Given this list of marker genes COX4I2, SMPD2, GSR, MED14, NEU4, CPNE1, TAT, NUP205, INS, DCXR, MAOB, PXMP2, AKR1C1, ADH4, GPS2, SLC25A32, ATIC, COQ9, GGT5, PLEKHA4, PIK3CD, DSE, NADK2, BCAT2, COQ8A, MPST, PCK1, MTF1, B4GALT1, ENO4, DUOX1, BMX, OGN, AGL, ETHE1, RAE1, NDUFA13, PM20D1, GCHFR, PSMA6, OMD, UGT2B7, NUP155, HS2ST1, LRP12, PIK3R1 (phosphoinositide-3-kinase regulatory subunit 1), ADH7, TH, NAALAD2, NT5C3A, TBXAS1, UQCRQ, SACM1L, CYP2D6, MPC2, CTH, SLC25A17, SLC25A15, THRAP3, B3GNT4, PIP4K2B, ST3GAL2, SLC46A1, DGAT2L6, RPS6, ST3GAL5, GPC4, PNKD, ODC1, MED24, NCOR2, RHCE, GSTM5, PGLS, CARNMT1, 5.8S rRNA, GYG1, HYAL4, NNT, ALOXE3, MSMO1, GAMT, LPIN2, IMPDH1, PSMC3, PRKACG, PSMB6, AGMAT, PKM, RBP1 (NCBI Gene Id 5947), HAS3, GSTT2, NSDHL, ACSF2, VAPA, OXCT1, UGT2A3, UGT2B11, HILPDA, PFKL, PECR, GPX1, HPGDS, PLCB3, PLAAT4, APOA1, NMT1, BLVRB, INPP5D, ACMSD, MED30 (NCBI Gene Id 90390), ACP6, RPS29, DDHD1, PDZD11, ABHD10 (abhydrolase domain containing 10, depalmitoylase), TTPA, NDUFB11, RPL39L, NME1, PSMC2, MIOX, SGPP1, GPAM, PI4KB (phosphatidylinositol 4-kinase beta), NEK1, TRIB3, COX6B1, UST, NADSYN1, RPL22L1 (ribosomal protein L22 like 1, NCBI Gene Id 553116), PIK3CG, BCKDK, TECRL, PSMD2, CYP1A2, COX7A2L, HAAO, VNN1, ADSL, GK3, GNG3, CHST15 (NCBI Gene Id 9916), PEX11A, HS6ST3, BST1, ACOT8, APIP, AKR1E2, CSAD, PITPNM2, PIK3CB, OSBPL7, SCP2, NOSIP, ACER1, GCLM, CPNE7 (copine 7), NDUFB7, CYP2F1, MBOAT2, RMND5B, SEPHS2, HK2 (hexokinase 2), PLA2G5, MED29, EBP, GATM, IDH2, GDPD3, RPL5, CYP2R1, HS3ST2, GSTA1, CHST14, UBC, PLAAT1, ADSS2, SLC23A2, STARD5, ACY3, ALOX12B, CLOCK, AMN, SAT1, HKDC1, DGUOK, ASNS, FBP2, ORMDL3, ACBD7, NAGLU, NAMPT, GNA14, SQOR, RPL11, HMGCR, PRELP, PSMA5, AKR1B1, RPL39, NFS1 (NCBI Gene Id 96810), FECH, SERINC2, NDUFS6, MTMR1, RPS9, SEM1, RPIA, GSTA5, LDLR, COX8C, CYP2B6, AMACR, PIP4K2C, GPT, TIAM2, SERINC1, SYNJ1, MCEE, AZIN1, GPX2, RPS7, TSTD1, MED1 (mediator complex subunit 1), MT-CO3, SLC36A4, RAN, FAM20B, AGPS, ACADS, CSGALNACT1, GNGT2, OAZ3, NUDT16, PSMA4, MCCC1, ARSD, SDC2, EXT2, MMADHC, RRM2B, PDP1 (pyruvate dehydrogenase phosphatase catalytic subunit 1), ACOT2, PSMD8, EXTL2, CHSY1, B3GNT7, DCAKD, ADH1B, SARDH, APOC2, TECR, MAT1A, LRP2, PANK1 (pantothenate kinase 1), CAV1, TPH2, SDHD, CHRM3, ADPRM, GALT, CPOX, COX11, GSTA4, NMRK1, GNAQ, CDIPT, RPL36A, PON2, DBI, L2HGDH, RPS19, CYP19A1, CYB5B, UGT1A9, HSPG2, HSD17B8, MED19, MT-ND4, GNG4, RPS16, ACAD9, NDUFAB1, NQO2, ARSI, PLPP2, BCKDHA, NAXD, PSMC1, SYNJ2, ENTPD2, PLA2G10, OAT, AMPD3, PTDSS1, SDS, OAZ2, SLC27A5, RPL9, UGT1A5, CSNK1G2, DCTD, RPS15A, MOGAT3, SLC22A13, PCYT2, ALOX15, NME3, ACSL1, TPST2, SCO2, OSBPL1A, ESD, PIP5K1B, AGRN, RPL36, AADAC, CACNA1D, GGT7, DBT, NUP85, CYB5R3 (cytochrome b5 reductase 3), SERINC5, SUCLG1, GBA1, ENTPD1, D2HGDH, HMGCS2, PLA2G4B, UGT3A2, GSTO2, SEC24C, GLUD1, MED25, STARD3, CYC1, HMBS, HIBADH, ALOX15B, SEPSECS, CYP26B1, HSD17B10, GLA, INPP5J, LYPLA1, PSMB2, TPK1, APOA2, INPP1, FIG4, DMAC1, PIK3C2G, SURF1, RPL15, AS3MT, HMOX1, HSD17B3, COX17 (cytochrome c oxidase copper chaperone COX17), EEFSEC, CYP4F22, AUH, CYP2A7, NUP35, RPLP0, ITPK1, NUP43, PLEKHA1, ALAS2, NDUFC1, ME1, GPAT4, PPIP5K2, DGAT2, RPL31, CTPS1, PSMB5, LIPE, ECSIT, UCP3, FUT9, FUT4, LDHC, AKT1, SIN3A (NCBI Gene Id 25942), PCBD1, FH, ALAS1, CYP4A11 (NCBI Gene Id 1579), SHMT2, UQCC2, UQCRFS1, MTMR8, GLB1L2, GLYATL3, SMOX, IDI2, DHRS7B, HSP90AB1, OSBPL9, PARP8, HACL1, ADH6, AGPAT3, NDUFS3, PLCH2, HOGA1, ISYNA1, RPS12, INPP5B, VAMP2, ATP5MJ, LDHAL6B, RPS8, SLC25A2, CHST9, ACAD10, NDUFA2, ADCY4, CGA, GPC5, POR, RPL26L1 (NCBI Gene Id 51121), NQO1, INSIG1, TMLHE (NCBI Gene Id 55217), ELOVL3, FMO1, FDFT1, GNAI1, GDPD5, FABP12, SPTSSA, NDUFB1, 28S rRNA, SMPD1, AK7, SQLE, IARS1, PTGR2, NDST2, AGPAT1, LETM1 (NCBI Gene Id 3954), NUDT15, PANK4, FUT1, HMOX2, CYP2C18, AKR1D1, PPP2R1B (protein phosphatase 2 scaffold subunit Abeta), PARP16, DPYD, RPL22, ADCY8, TACO1 (translational activator of cytochrome c oxidase I), RMND5A, ARF3, GOT1, AK1, CACNB2, PITPNB, HPDL, NUDT13, CERS5, SLCO1A2, PPP2CB, PIAS4, TIMM21, ENTPD6, TST, GSTM2, PLA2G4D, DCT, CA7, CKB, NR1H4, GDPD1, PTGDS, ATP5PB, SUCLG2, PLA2G4E, NR1H2, UQCC3, UCK2, PAH, AOC1, RPS2, NDUFA11, PRKAR2A, PGS1, PFKFB1, ACY1, SLC25A18, PISD, CTRB2, PANK3, ST3GAL3, PIPOX, GLRX, BHMT2, INPP5F, FAR1, ACAT2, TBL1X, NDUFAF8 (NADH:ubiquinone oxidoreductase complex assembly factor 8), ACOT9, PLCG2, NUDT18, LTC4S, NT5C, CDS1, CD44 (NCBI Gene Id 960), SPAM1, CPNE3, PSMA3, RPL7, NUDT10, AHCYL1, SNAP25 (synaptosome associated protein 25), BPNT2, PNPLA8, HELZ2, IL4I1, FAU, MOCS1, PIK3R6, FABP4, PPA1, MED17, NUP58, GSTT2B, UGDH, CYP39A1, NUP133, ACSBG2, SULT6B1, RBKS, RPL32, SUCLA2, SLC35D2, GLS, CYP51A1, PGK1, DHCR7, HSD11B1, KCNJ11, PNP, NUP214, DNM2, AOC2, MED31, UQCR10, GNAI2, ACADSB, PSMB3, PSMA1, AKR7A3, OPLAH (NCBI Gene Id 55579), NDUFS5, GLB1L3, ARG1, FUT6, MDH1, GGPS1, MLX, WDR26, PSMD6, ALDH1A1, ENO3, MARCKS, CBR1, GNG12, CES1, ALDH1B1, HS3ST3A1, PFKM, TPMT, ACOT7, GADL1, HAO2, PLPP3, SULT1E1, STAR, PPP2R5D, ABCA1 (ATP binding cassette subfamily A member 1), RFK (NCBI Gene Id 55312), ACAN, DEGS2, HSD11B2, B3GAT2, PNPLA6, GNB5, PANK2, COX6A2, PIP5K1C, AKR1A1, NDUFB4 (NCBI Gene Id 727762), CYP26A1, PLEKHA6, PIK3C2B, CYP27A1, RRM1, AMT, ACLY, CDO1, CA6 (carbonic anhydrase 6), MED21, SULT2A1, PLPP1, MT-ND3, MAT2B, CACNA1E, FDX1, SLC51A, BAAT, ACSM6, FDPS, RPL35, DIO3, ALDH2, ECI2, PLCB4 (NCBI Gene Id 5332), SULT2B1, NUDT5, B4GALT3, SLC26A1, FAH, ATP5PO, LPL (NCBI Gene Id 4023), ARSF, FOLH1, RPS21 (ribosomal protein S21), NDUFA1, HAL, SLC26A2, NUBP2, CYCS, DEGS1, ELOVL4, CACNB3, PPARGC1B, AK8, RPL6, GSTM4, CHST3 (NCBI Gene Id 9469), ACSS1, ARSL, PARP9, SLC25A13, ADPGK, RPS13, ATP5ME, RAB14, ACOXL, XYLT2, RIDA, FITM1, SPTLC1, NDOR1 (NCBI Gene Id 648245, NADPH dependent diflavin oxidoreductase 1), FITM2, MED18, COASY, MOCOS, MOGAT1, FABP1, NUDT9, DLAT, ADCY7, MED4, TYMS, CHST1, CA1, RPS27, AGK, CA14, COX7C, PRKACB, RPS24, NDUFB3, CYP2C19 (cytochrome P450 family 2 subfamily C member 19), COMT, SEC23A, ACACB, NMNAT2, CD36 (NCBI Gene Id 948), NDUFS7 (NADH:ubiquinone oxidoreductase core subunit S7), KYAT3, CA5A, NMRAL1, PYGB, CYGB, PLBD1, RPS23, CSPG4, GC, COX8A, ADCY1, RPL23A, AGXT, PFKFB2, PLA2G4F, COQ8B, ABCD4, VNN2, FABP6, IP6K1, AACS, HPSE, NT5C1A, INPP5E, ACP5, AMD1, PIK3C2A, CAD, SCAP, STS, CD38 (NCBI Gene Id 952), UGT1A3, CYP24A1, ME3, SLC25A51, NDUFS1, ABHD4, SLC27A2 (solute carrier family 27 member 2), CIDEC, ALDH3A2, NDUFAF7, UGT2B10 (UDP glucuronosyltransferase family 2 member B10), GOT2, GPD2, MTM1, NR1D1, TK1, MED22, PIK3C3, PRPS2, INPPL1, AZIN2, KERA, SLC35B3, CBLIF, CYP2C8, HK3, CYP46A1, MTMR6, DMAC2L, RPL19, DDAH1, SLC25A14, RPL37, SIRT5 (NCBI Gene Id 285813), 5S rRNA, UPP2, CEMIP, CHSY3 (NCBI Gene Id 337876), IPPK, IPMK, MAT2A, RPL18A, IVD, PIK3R5, UGT1A8, PDK2, CHST7, TSHB, INPP5A, DARS1, GCK, BGN, HADHB, STARD6, B3GALT2, GLIPR1, SLC25A44, RPL30, CERS3, GCG, NUP107, FUT5, TKT, GSTM1, CERS1, GGT6, RPE, PNPLA7, B3GALT5 (NCBI Gene Id 105372805), PRPS1, PLA2G6, PLEKHA8, ALDH7A1, PLIN1, CERS2, GNG13, PUDP, ELOVL5 (ELOVL fatty acid elongase 5), ERCC2, AK9, POM121, HAO1, CYP1B1, FDX2 (NCBI Gene Id 2143), UGT2B15, SPHK2, RPL10, INMT, B3GNT2, STARD3NL, SLC37A4, MMUT, COQ7, RPL18, NUDT4, UQCRB, RPL37A, HAS2, GGT3P, UQCRHL, ENPP2, STAB2, NMRK2, GGCT, NPAS2, NUP160, HEXA, PDXK, RPSA, AK5, NDUFA6, CYP17A1, NDUFB9, LPIN1, CYP7A1, FTCD, UCP1, TNFAIP8L2, CHST5, MT-CYB, ANKRD1, HYKK, NDUFA7, BCO1, AHR, CSNK2A1, UGT2A1, CA12, ACSF3, SUMO2 (small ubiquitin like modifier 2), PRSS3, HMMR, PC, TXNRD1, NDC1, ADCY2, PSMB4, ADI1, BCO2, XYLT1, CYP4F3, A4GALT, RPL12, SEC24D, PLB1, SLC52A2, CYP11B1, PTGES3, FAHD1, ACOT13, TMEM126B, PLD2, GUK1, CHAC1, NUDT3, GMPR, PRKACA, RUFY1, PYCR3, PLA2G2E (phospholipase A2 group IIE), PGM2, MTHFD2L, DCTPP1, DIO2, BTD, OCRL, SMARCD3, GCH1, PPIP5K1, PLA2G15, SREBF1, GALC, B3GALT6, ACAA2, SLC25A37, AOC3, SDHC, HIGD1C, SERPINA6, NRF1, RPL27, HYAL1, PLD1, CYP2U1, CYP7B1, TPH1, IDI1, FLVCR1, GCSH, CD320, ALDH4A1, SULT1C4, G6PC2, MTRR, CHAC2, MED7, PDPR, ABO, STARD10, GPC2 (glypican 2), DHFR2, UGCG, UPB1, GPC3, GNA15, PPM1K, APOA5, LRAT, SLC44A1, ITPR3 (NCBI Gene Id 3710), CCNC, TP53, GSTT1, CYP2S1, GNG5, EPHX2, UQCRC1, SARS1, GYS1, PSMC6, LPCAT1, HGD, CIAO1, PARP4, ACOT1, HSD17B14, AIMP1, LGMN, CSNK2B, AANAT, SDSL, THEM4, DDO (NCBI Gene Id 8528), SLC52A1, TPST1, PGAM2, UBB, AK6, GPC1, ACAD8, HCCS, COQ10A, ETFA, PPAT, HSD17B4, ENOPH1, RARS1, ORMDL2, RPLP2, CSPG5, ATP5MC2, CALM1, HSD17B2, GNA11, RPL38, CYP2J2, PAOX, DTYMK, PHKA1, UBIAD1 (UbiA prenyltransferase domain containing 1), PRKAR1B (NCBI Gene Id 645590), SECISBP2, PYGM, CRYM, HSD3B2, PGD, NFYB, SLC2A1, RRM2 (NCBI Gene Id 6241), PODXL2, ATP5MC3, ATP5PD, MORC2, SERINC4, SLC6A7, GLP1R, FMOD, PPP1R3C, TNFAIP8, PSMD1, AKR1B15, HAGH, ADH1A, ACSL4, NUP42, GMPR2, IQGAP1, APOA4 (NCBI Gene Id 337), CHST6, ENTPD5, PSMB7, AK4, SC5D, MTHFD1, SLC19A2, NUP50, AADAT, TRMT112, AGPAT2, UQCRC2, TRAP1, G6PD, FADS2, DMAC2, MTARC2, SLC5A5, MBTPS2, VDAC1, HS3ST4, RPL34, PGM1, PXYLP1, DECR1, CHDH, MED10, PARP6, PSMC4, SPR, FLAD1, PITPNM1, OLAH, SPTSSB, DERA, TXN, LPCAT3, NNMT, LHB, UQCC1, TNFRSF21, STK11, RPL14, CUBN, B3GAT1, FABP5, UQCRH, PDHB, RAB5IF, BBOX1, RPS15, MMACHC, HACD2, NUP153, PCK2, ELOVL1, NT5C1B, PSMD3, PLAAT2, ADA, GID4, GMPS, PPM1L, NUBP1, DPEP1, CYP2C9, ABCC8, RPL13A, ALOX5AP, RPL10A, GSTO1, GART, SLC25A21, NDUFB6, CA3, CYP3A4, STXBP1, MT-ND2, SRD5A2, COQ2, RPS3, PTGES, ATP5MF, GAPDH, ISCA2, MT-ATP6, UQCC5, CBR3, ADCY6, CSKMT, ATP5MK, FHL2, GYS2, UGT1A1, STARD7, AKR1C4, CHST13, DDHD2, HACD3, PLCB2, AKAP5, PPARA, MED27, INPP4A, POM121C, CA9, COA3, SGMS1, AMDHD1, SLC22A5, HIGD2A, NT5C2, CYP11A1, UGT1A4, ADIPOQ, KPNB1, SLC35D1, CA4, NUP62, HSD17B12, SDHAF3, B3GNT5, CIAO2B, TYMP, PLAAT5, GNAS, DLD (NCBI Gene Id 2654), PNPO, SDC1, CA2, COX6C, GID8, SLC37A1, ACSM2B, FOLH1B, CMBL, CERT1, ACOX1, THEM5 (thioesterase superfamily member 5), ALDH1L1, GNG8, COX5A, IDO2, PNPLA2, OXCT2, GALNS, MINPP1, MAOA, APOB, UROS, GLB1, SLC6A12, OSBPL10, SDC3, DBH, ZDHHC21, CARNS1, IMPA2, RPL35A, GLUD2, GK, CYP4V2, HK1, PHKG1, ETNK1, SLC5A8, ADCY5, SRM, PMVK, ATP5MC1, PLA2G3, FABP7, PEMT, TYRP1, HADHA, TGS1, MBTPS1, NDUFS8, SLC44A4 (solute carrier family 44 member 4), EPM2A, PET100, ACER3, RPL17, MED26, ENTPD4, GPC6, ADCY9, PRKAA2, HSD17B7, ABCC5, OSBPL8, ACSBG1, PRKCA, HSPA9, PTS, PYCR2, CSGALNACT2, CHD9, PRXL2B, IP6K2, ENPP3, SLC22A4, ITPR1, SLC17A5, ACSL6 (NCBI Gene Id 56972), GCLC, CMPK1, CACNA2D2, CHPF2, GLYAT (NCBI Gene Id 10249), RNLS, SPNS2, NDUFB5, SCO1, RPS25, ASPA, MED12, GPX4, NCOR1, B3GNT3, SLC9A1, ACADVL, FAAH2, ABCB7, GNPAT, CKMT1A, PIKFYVE, G6PC1, ALOX12, ALDH1L2, DLST, UGT1A10, ACAT1 (acetyl-CoA acetyltransferase 1), NDUFA8, CYP4F11, BPHL, PSAP, G6PC3, KARS1, GNMT, NCOA6, CACNA1C, NFYA, SLC37A2, NAT1, MFSD2A, GLUL, SLC52A3, PSMA2, B4GALNT2, ACSM3, IP6K3 (inositol hexakisphosphate kinase 3), SLC25A4, NT5E, ALDH3B2, PNPLA3, RPL3L, CYP4F12, ACADL, GK2, TCN1, HPD, ARG2, RPL7A, INPP4B, NDUFC2, CPS1, RPL36AL, PRKD3, RPS3A, MT-ND1 (mitochondrially encoded NADH:ubiquinone oxidoreductase core subunit 1), MTAP, SULT1A1, MTMR12, RPL41, AGPAT4, UGT1A7, SUOX, GALK1, IDS, GLB1L, CYP2W1, ARMC8, ALB, GSTP1, RDH11, CHKA, ARNT2, 18S rRNA, NMNAT1, RPL4, ACOT7L, PIK3CA, HYAL2, RPL27A, EHHADH, GNGT1, SDHB, PLPP6, NDUFV2, ISCU, NCOA1, NUP98, LCLAT1, PGAM1, RAB5A, RETSAT, ITPA, CACNA1A, GNS, PLAAT3, CERK, SLC6A11, COX7A2 (cytochrome c oxidase subunit 7A2), SLC19A3, CPT1A, PARP14, LPCAT2, NR1H3, PGAM5, EPRS1, HNMT, SLCO1B3, ENPP7, FAM120B, DIO1, APOM, STX1A, MAPDA, NUP188, LYRM2, CYP4A22, MMAB, CYP8B1, BCKDHB, AGXT2, GPAT3, RTEL1, KCNC2, RIMKLA, CERS4 (NCBI Gene Id 79603), PSMC5, NUP93, FUT3, SLC27A3, MTMR14, SEC24B, UGT1A6, GNB2, INPP5K, POLD1, SLC6A8, PHOSPHO1, ACAD11, MTHFD2, SPTLC3, SLC45A2, MED20, PNPLA5, SYT5, HYAL3, NDUFA3, TALDO1, ADSS1 (NCBI Gene Id 122622), RXRB, SAMD8 (NCBI Gene Id 142891), B3GALT1, GPT2, EP300, MTMR7, TNFAIP8L3, MTMR3, SUMF1, APRT, TTC19, G0S2, HS3ST3B1, APOE, UQCR11, RPS4Y2, ACO2, DMGDH, NAXE, PPA2, KCNG2, PSMD14 (proteasome 26S subunit, non-ATPase 14), NDUFS4, KMO, SCD5, KCNB1, MOCS3, CYP2A13, MAN2B2, ABCB11, ADRA2A (adrenoceptor alpha 2A), CERS6, NUDT19, IDO1, HMGCLL1, PRSS1 (NCBI Gene Id 5644), MCCC2, B4GALT7, OSBPL3, PHGDH, ME2, QARS1, PNLIP, COX4I1, ARSB, NDUFV1, DHODH, SLC25A28, RPS27L, NDUFAF5, TK2, SMS, UPP1, PITPNM3, PDP2, MED13L, AGPAT5, INSIG2, AASDHPPT, NUP210, ABCD1, PPT1, OAZ1, MT-ATP8, PDSS2, EXT1, ETFB, RPS14, ABHD3, VCAN, ALDH18A1, ABCG2, SIRT4, FASN, LRP8, TXN2, AGMO, CRYL1, NUDT11, PCYT1A, PLA1A, AIMP2, SHMT1, PLEKHA3, LYRM4, ST6GALNAC5, MLXIPL, B3GALNT1, APOC3, LDLRAP1, PGP, MTHFD1L, CYP27B1, ALAD, LPGAT1, RPS18, TCN2, ASAH2, NDUFAF6, UGT8, SLC7A5, LUM, SLC25A42, MED11, PDK4, ECI1, NOS3, ALDOA, BDH2, GSTK1, LBR, PON3, DNPH1 (2'-deoxynucleoside 5'-phosphate N-hydrolase 1), NDUFA12, SLC10A2, MECR, DECR2, UGP2, UBE2I, GAL3ST1, ARV1, CPNE6, WASL, NDUFA10, PRKD2, SLC44A2, NT5M, GBA2, BPGM, NOSTRIN, MGST3, LDHA, AKR7A2, PSMD12, PAPSS1, OSBPL5, PCTP, UBA52, HS3ST6, SLC19A1, TPTE2, SMIM20, HIGD1A, ABCC3, PLCB1, ACOX3, NEU1, COA1, MANBA, HDC, SLC25A10 (solute carrier family 25 member 10), HS6ST1, PKLR, ASAH1, AHRR, MVK, B4GALT2, PHKB, OTC, PLA2G2D, PRKAB2 (NCBI Gene Id 5565), ST8SIA5, AOX1, LTA4H, OCA2, SLC25A20, NDUFA5, SDHAF4, HEXB, MMAA, PTGIS, GNPDA2, GPAT2, SHPK, ATP5F1B, MRI1, PTGS1, FMO3, PLD6, NDUFB2, NDUFAF3, COQ3, PRODH2, VDR, CMC1, ATP5F1A, SUMF2, CREBBP, GYG2, IDH3G, GCGR, PSMA7, PARP10, MTARC1, MTR, MAN2B1, TPTE, MED28, LHPP, PRKAR1A, LPCAT4 (NCBI Gene Id 91188), PIP5K1A, PSMD13, SCD, RPLP1, ITPKB, AKR1B10, HSD17B11, SGMS2, CHST12, ACHE, PLEKHA5, PLD4, LSS, NAT2, RPS26, RPL28, MED6, CRAT, MED15, ARSH, MTHFR, SRR, CYP3A43, HSD17B13, RPL13, PSPH, ACOT4, COX18, UXS1, B4GALT4, PSTK, PDHA2, CYP4F8, ADCY3, ST3GAL6, CIAPIN1, ALPI, FAR2, SLC35B2, GSTA3, CHST2, GDE1, BCHE, SEH1L, CYP4F2, PLCE1, ACBD5, ST3GAL1, PI4KA, GAPDHS, RPL23, PRKAG2, ACSM5, GALE, CYB5A, CTSL, SFXN4, KYAT1, ACOT11, MFSD2B, ACSS2, CHPT1 (NCBI Gene Id 56994), MT-CO2, DHFR, MT-CO1, TAFAZZIN, QPRT (quinolinate phosphoribosyltransferase), ACSL5, MTHFS, SAR1B, CDK8, NDUFA9, UMPS, TMEM86B, NAPRT, SRD5A1, GLDC, ABCC1, ABCB4, PSMB1, ECHS1, RBP4, MTMR10, IDH3A (isocitrate dehydrogenase (NAD(+)) 3 catalytic subunit alpha), AAAS, PLCZ1, SLC25A16, CDK19, UROD, RPEL1, PGM2L1, PLA2G4A (phospholipase A2 group IVA), FMO2, RIMKLB, PTGES2, ASS1, RANBP9, PAPSS2, GM2A, COXFA4, DUOX2, SLC44A3, PDHA1, RPS17, PHYKPL, MED13, ENO1 (enolase 1), TKFC, GPCPD1, FAAH, PCCB, LDHAL6A, FBP1, SLC2A3, HGSNAT, SAMHD1, RPS28, TMEM126A, GPD1 (NCBI Gene Id 2819), RAP1A, ACER2, NDUFV3, FADS1, RPL10L (ribosomal protein L10 like), CYP21A2, COQ10B, PPP1CC, SLC25A12, AKR7L, FOXRED1, NMNAT3, TM7SF2, ALDOC, FA2H, PIK3R3, SLCO1B1, PIP4P1, ATP5F1E, RPL8, AGT, PTGS2, ETNPPL (ethanolamine-phosphate phospho-lyase), ALOX5, XDH, NEU3, ADH5, B4GALNT1, DCK, SPHK1, PLCD4, LMBRD1, PPARG, RPS4Y1, FOLR2, CDS2, MT-ND5, HSCB, CSNK2A2, CDA, MGLL, MPC1, AASS, BDH1, HSD3B7, GNG11, DHCR24, PON1 (paraoxonase 1), ST3GAL4, ENTPD8, PRKG2, TMEM186, PPARD, DHTKD1 (NCBI Gene Id 79141), PFKP, HMGCL, PRODH, NCOA2, PRKAR2B, CYP3A7, GNB4, PLA2G4C, CBR4 (NCBI Gene Id 84869), SLC23A1, NUDT1, NDST1, AIP, TIMMDC1, B3GALT4 (NCBI Gene Id 87866), PNMT, LARS1, ENPP6, CA5B, UGT2B28, PLCD1, RAB4A, NUP54, ATP5PF, ARSJ, PPARGC1A, SORD, AKR1C3, NUDT12, MED16, NME4, SLC51B, ACO1, DUT, CYP2E1, PTGR1, FPGS, PPOX, ASRGL1, LRP1, SULT1B1, GLYCTK, ISCA1, EPHX1, PTDSS2, M6PR, PGK2, KHK, ITPR2, MGST1, ADH1C, TDO2, FXN, GBE1, SULT1A4, NUBPL, XYLB, RPL21, SPTLC2, SDHAF1, FUT2, RAPGEF4, TSPOAP1, HTD2, DDC, DSEL, SLC44A5, CYP26C1, CYP3A5, GNB1, NDUFB10, TPI1, SLC25A22, PCCA, ASMT, ATP5MG, HPGD, HSD3B1, B4GALT6, ARSK, ENTPD3, HLCS, MDH2, COX20, NADK (NAD kinase), TNFAIP8L1, GLYATL2, MBOAT7, CES3 (carboxylesterase 3), GNB3, ENTPD7 (NCBI Gene Id 57089), SULT1A2, PPT2, ELOVL2, AKR1C2, ESRRA, SIN3B, MAEA, MGST2, DCN, ACSS3, PI4K2A, MT-ND6, CYP1A1, RAPGEF3, ELOVL7, DAO, RPL24, ITPKC, SGPP2, COQ6 (coenzyme Q6, monooxygenase), PPCS, OGDH, GRHL1, PIK3R4, PIP4K2A, SERINC3, TPO, B4GALT5, IMPA1, BRIP1, NCOA3 (nuclear receptor coactivator 3), UCKL1, OSBPL6, NDUFS2 (NADH:ubiquinone oxidoreductase core subunit S2), ORMDL1, HSD17B1, CKMT2, GNG2, TMEM177, MAPKAPK2, ALDH3B1, PTEN, PLA2R1, SLC5A6, COX15, PLIN2, PSAT1, PDSS1, PPP1CB, GSTZ1, ETNK2, GNG10, IMPDH2 (NCBI Gene Id 3615), TBL1XR1 (NCBI Gene Id 81612), UGT2B17, SLC26A11, DGAT1, COX7A1, DPEP2, COX10, COX19, ARNT, TXNDC11, PLIN3, DPYS, QDPR, CA13, CBS, GPIHBP1, SELENOI, VAC14, PSMD11, SLC3A2, ACAA1, NDUFAF4, SLC2A2, ATP5F1C (NCBI Gene Id 511), PLA2G12A, PPP2CA, CTSA, ARSG, RBP2, MOCS2 (molybdenum cofactor synthesis 2), TYR, KGD4, THRSP, PLD3, PYURF, GLO1, FUT7, CLPS, ASL, COQ5, ADRM1, HS3ST5, OSBP, SULT4A1, MED23, NME2, NMT2, ACSM4, RXRA, NUDT8, ARSA, ETFDH, ADK, EXTL3, SEC24A, VKORC1, PCYT1B (NCBI Gene Id 9468), SP1, SLC25A11, CTRB1, AMPD2, LIPH, NAGS, PAICS, PPCDC, SIRT3, GGT1, SLC25A19, B4GAT1, IDH3B, ALDH9A1, COQ4, ACSM2A, MKLN1 (NCBI Gene Id 55782), ACBD6 (NCBI Gene Id 84320), MIGA1, LRP10, AK2, GLRX5, GDA, NFYC, GLS2, HADH, GSTA2, PDK1, SBF1, NCAN, PYCR1, SLC10A1, PLEKHA2, ADIPOR1, BCS1L, BCAT1, RPS20, TSPO, TMEM223, MMS19, UGT2B4, RPS4X, PTPN13, GPI, EEF1E1, SMPD4, CARM1, IYD, AWAT2, FABP2 (fatty acid binding protein 2), THTPA, CYP4B1, RPL26, SULT1A3, PFAS, RPS5, LYRM7, PI4K2B, COA5 (NCBI Gene Id 493753), FABP3, HAS1, HMGCS1, PLA2G2A, CES2, ACBD4, ANGPTL4, HIBCH, MTMR9, ENPP1, MID1IP1, MAN2C1, MPC1L, RPL3, HDAC3, ADHFE1, CHKB, COX16, BHMT, GSS, GNPDA1, CKM, RPL29 (NCBI Gene Id 6159), NDUFAF2, PRKD1 (protein kinase D1), CNDP2, MIGA2, CHP1, MARS1, CHAT, PNPLA4, CPT1B, CS, HACD1, MVD, NDUFAF1, GPHN, COX14, NDST4, GCDH, SDHA, ADRA2C, CH25H, RPS27A, CYP2A6, CHPF, PLCG1, COX7B, PHKG2, ACSM1, MLYCD, HACD4, ITPKA, PTPMT1, MED9 (mediator complex subunit 9), NHLRC1, B3GAT3, MBOAT1, CIDEA, HS6ST2, HEMK2, OXA1L, GRHPR, BPNT1, PFKFB3, NDUFB8, PYGL, ENO2, UQCC6, SMPD3, ACOX2, BMAL1, GPD1L, SRD5A3, COX6A1, TTR (NCBI Gene Id 7276), ACACA (NCBI Gene Id 31), LPIN3, MCAT, ACSL3, ATP5F1D, DUOXA1, KYNU, PPP1CA, PSMD7, ARF1, ALDOB, RHD, SLCO2B1, UGT3A1, VKORC1L1, UCK1, ST6GALNAC6 (NCBI Gene Id 30815), PLCD3, ABHD14B, MTMR2, SULT1C2, RORA, SBF2, COX5B, PPP2R1A, UGT2A2, ASPG, GAA, COX6B2, HSP90AA1, PLCH1, TPR, GALM, PFKFB4, CPT2, GLCE, CYP11B2, PRPS1L1, NUDT7, AWAT1, KCNS3, PDK3, NAT8L, FABP9, ACADM, ALDH6A1, CTPS2, GCKR, GSTM3, DUOXA2, KDSR, MOGAT2, CHST11, PLA2G1B, HPRT1, PHKA2, PDHX, AHCY, NME6, PET117, GBA3, CRLS1, IDUA, HS3ST1, SEC13, LALBA, CIAO3, NUP37 (nucleoporin 37), NDST3, FFAR1, ALDH3A1, UCP2, HPSE2, AMPD1, AFMID, SCLY, RANBP2, RGL1, UROC1, MTMR4, SLC27A1, FDXR, ABCC2, SDC4, SGSH, OSBPL2 (oxysterol binding protein like 2), GUSB, ELOVL6, PIK3R2, SDHAF2, RPS10, ABHD5, ADIPOR2, SGPL1, RPS11, STARD4, IDH1, BLVRA, VAPB, ADO, CROT, SLC25A27, SREBF2, POMC, CEPT1 (NCBI Gene Id 10390), BCAN, LIPI, GNG7, NEU2, PLA2G2F, GLYATL1, LDHB, MED8, ACOT12, NUP88 (nucleoporin 88), PHYH, LYVE1, here is a description of the gene set: studied in species Homo sapiens Reactome Pathway: Metabolism Metabolic processes in human cells generate energy through the oxidation of molecules consumed in the diet and mediate the synthesis of diverse essential molecules not taken in the diet as well as the inactivation and elimination of toxic ones generated endogenously or present in the extracellular environment. The processes of energy metabolism can be classified into two groups according to whether they involve carbohydrate-derived or lipid-derived molecules, and within each group it is useful to distinguish processes that mediate the breakdown and oxidation of these molecules to yield energy from ones that mediate their synthesis and storage as internal energy reserves. Synthetic reactions are conveniently grouped by the chemical nature of the end products, such as nucleotides, amino acids and related molecules, and porphyrins. Detoxification reactions (biological oxidations) are likewise conveniently classified by the chemical nature of the toxin.<p>At the same time, all of these processes are tightly integrated. Intermediates in reactions of energy generation are starting materials for biosyntheses of amino acids and other compounds, broad-specificity oxidoreductase enzymes can be involved in both detoxification reactions and biosyntheses, and hormone-mediated signaling processes function to coordinate the operation of energy-generating and energy-storing reactions and to couple these to other biosynthetic processes.